The following is a description of a gene set: Genes up-regulated in M2-10B4 cells (osteoblast) in response to phenylamil. Mouse Gene Set: PARK_OSTEOBLAST_DIFFERENTIATION_BY_PHENYLAMIL_UP Stimulation of osteoblast differentiation from mesenchymal stem cells is a potential strategy for bone repair. Bone morphogenetic proteins (BMPs) that induce osteoblastic differentiation have been successfully used in humans to treat fractures. Here we outline a new approach to the stimulation of osteoblast differentiation using small molecules that stimulate BMP activity. We have identified the amiloride derivative phenamil as a stimulator of osteoblast differentiation and mineralization. Remarkably, phenamil acts cooperatively with BMPs to induce the expression of BMP target genes, osteogenic markers, and matrix mineralization in both mesenchymal stem cell lines and calvarial organ cultures. Transcriptional profiling of cells treated with phenamil led to the identification of tribbles homolog 3 (Trb3) as a mediator of its effects. Trb3 is induced by phenamil selectively in cells with osteoblastic potential. Both Trb3 and phenamil stabilize the expression of SMAD, the critical transcription factor in BMP signaling, by promoting the degradation of SMAD ubiquitin regulatory factor 1. Small interfering RNA-mediated knockdown of Trb3 blunts the effects of phenamil on BMP signaling and osteogenesis. Thus, phenamil induces osteogenic differentiation, at least in part, through Trb3-dependent promotion of BMP action. The synergistic use of small molecules such as phenamil along with BMPs may provide new strategies for the promotion of bone healing. studied in species Mus musculus from publication Park KW, Waki H, Kim WK, Davies BS, Young SG, Parhami F, Tontonoz P (PMID 19433444), and this is the list of marker genes: Aldh1l2, Chac1 (ChaC, cation transport regulator 1), Thbs1, Trib3, Slc6a9, Dlk2, Cyp26b1, Cldn1, Fst, Cox6a2, Rgcc, Rgs3